Given this list of marker genes Gpam, Tamm41, Agpat5, Agpat4, Cds1, Gpat3, Cdipt, Agpat3, Gpat2, Cds2, Lclat1, Agpat1 (NCBI Gene Id 55979), Agpat2, Gpat4 (NCBI Gene Id 55933), here is a description of the gene set: Mouse Gene Set: GOBP_CDP_DIACYLGLYCEROL_METABOLIC_PROCESS studied in species Mus musculus The chemical reactions and pathways involving CDP-diacylglycerol, CDP-1,2-diacylglycerol, a substance composed of diacylglycerol in glycosidic linkage with cytidine diphosphate. It is a common intermediate in phospholipid biosynthesis.